Given this list of marker genes Rsad2, Dennd1b, Prkcz, Gata3, Il6, Xcl1, Il4, Cd81, Nlrp3, here is a description of the gene set: Any process that activates or increases the frequency, rate or extent of T-helper 2 cell cytokine production. species: Mus musculus Mouse Gene Set: GOBP_POSITIVE_REGULATION_OF_T_HELPER_2_CELL_CYTOKINE_PRODUCTION